Given this list of marker genes Cycs, Sod2, Sirt4, Gabpb1, Glud1, Idh2, Gabpa, here is a description of the gene set: species: Mus musculus This event has been computationally inferred from an event that has been demonstrated in another species.<p>The inference is based on the homology mapping from PANTHER. Briefly, reactions for which all involved PhysicalEntities (in input, output and catalyst) have a mapped orthologue/paralogue (for complexes at least 75% of components must have a mapping) are inferred to the other species. Reactome Pathway: Transcriptional activation of mitochondrial biogenesis part of: Mitochondrial biogenesis electronically inferred by orthology from the curated human pathway